The following is a description of a gene set: Mouse Gene Set: MIR_3079_3P_MIR_7080_3P studied in species Mus musculus from publication Chen Y, Wang X (PMID 31504780) Genes predicted to be targets of miRBase v22 microRNA mmu_miR_3079_3p, mmu_miR_7080_3p in miRDB v6.0 with MirTarget v4 prediction scores > 80 (high confidence targets)., and this is the list of marker genes: Acad11, Acsl4, Fgfbp3, Spred2, Golm2, Atp1b1, Mycbp, Negr1, Ogt, Dennd10, Ptpn9, Abcg3 (ATP binding cassette subfamily G member 3), Hivep2, Snx33, Avl9, Plod2, Usf3, Adpgk, Ube2q2, Per2, Tmem94, Klf11, Rpap1, Kmt2a, Phf20l1, Mcrs1, Fads1, Emc3, Phactr4, Sntg2, Drd1, Rasa1, Tenm3, Adss1, Kcnv2, Als2 (alsin Rho guanine nucleotide exchange factor), Ccn4, Ctbp2, Pgrmc2, Skor1, Rap2c, Caprin1, Rimklb, Tfam, Setd7, Secisbp2, Sec22a, Tjp1, Uhmk1, Igf2bp3, Virma, Srpx, Galc, Jarid2, Atpaf2, Cdc42ep2, Mras (NCBI Gene Id 73053)